Given this list of marker genes RBMS3-AS3 (NCBI Gene Id 100873979), RPL15, UBE2E2-DT, RN7SL216P, KLHL25P1, RPL31P20, PP2D1, EFHB, TGFBR2, RNU6-138P, LINC00692, NEK10, MIR3714, THRB-AS1, RPL34P11, RNA5SP125, SGO1, SALL4P5, RAB5A, UBE2E1, RPL24P7, HSPA8P18, MTND4LP9, PLCL2-AS1, ZNF385D, VENTXP4, RBMS3 (NCBI Gene Id 27303), RBMS3-AS1, LINC00690, NPEPPSP2, EIF3KP2 (eukaryotic translation initiation factor 3 subunit K pseudogene 2), LINC01980, PLCL2, UBA52P4, RNU6-822P, MICOS10P3, LINC01967, NR1D2, LRRC3B-AS1, LINC01981, C11orf98P3, AZI2, RBISP6 (RBIS pseudogene 6), RARB-AS1 (RARB antisense RNA 1), RNU4-85P, MIR3135A, VENTXP7, RARB, LRRC3B, THRB, RFTN1, RNU6-788P, RPL31P19, SATB1-AS1, LOC124906377, TPM4P2, RBMS3-AS2, NKIRAS1, DAZL, THRB-IT1, CFL1P7, RANP7, RNU1-96P, RRBP1P2, RPL39P18, RNU6-922P, RNA5SP126, THRB-AS2, BALR6, SAP18P3, ENSG00000299728, PP1P, KCNH8 (NCBI Gene Id 131096), UBE2E2, MIR4442, RNU6-815P, RNU6-342P, ENSG00000303350, MIR4791, RPEP2 (NCBI Gene Id 651011), EOMES, NPM1P23, TAF9BP1, PDCL3P3, FCRL4P1, HMGB1P5, CMC1, ZNF385D-AS2, ZCWPW2, KIAA1143P2, CRIP1P2, H3P10, CIAO2AP1, OXSM, TBC1D5, RPS27P11, KAT2B, RPS20P15, LINC00691, RPS12P5, RAD23BP1, CDYLP1, ARL4AP4, LINC02084, HMGB3P12, MESTP4, SATB1 (SATB homeobox 1), RNU7-10P, LINC01985, UBE2E1-AS1, SGO1-AS1, NGLY1, ZNF385D-AS1, SLC4A7, RPL32P11, TOP2B, here is a description of the gene set: Human Gene Set: chr3p24 species: Homo sapiens